The following is a description of a gene set: Pan-Hdac inhibitors (HDACi) are endowed with a potent anti-inflammatory activity, but the relative role of each of the eleven Hdac proteins sensitive to HDACi to the inflammatory gene expression program is unknown. Using an integrated genomic approach we found that Hdac3-deficient macrophages are unable to activate almost half of the inflammatory gene expression program when stimulated with lipopolysaccharide (LPS). A large part of the activation defect is due to loss of basal and LPS-inducible expression of IFNb, which in basal cells maintains Stat1 protein levels, and after stimulation acts in an autocrine/paracrine manner to promote a secondary wave of Stat1-dependent gene expression. We show that loss of Hdac3-mediated repression of nuclear receptors leads to hyperacetylation of thousands of genomic sites and associated gene derepression. The upregulation of the constitutively expressed prostaglandin endoperoxide synthase, Ptgs1 (Cox-1), has a causative role in the phenotype, since its chemical inhibition reverts the Ifnb activation defect. These data may have relevance for the use of selective Hdac inhibitors as anti-inflammatory agents. Human Gene Set: GSE33162_UNTREATED_VS_4H_LPS_STIM_HDAC3_KO_MACROPHAGE_DN from publication Chen X, Barozzi I, Termanini A, Prosperini E, Recchiuti A, Dalli J, Mietton F, Matteoli G, Hiebert S, Natoli G (PMID 22802645) species: Homo sapiens Genes down-regulated in macrophages with knockout of HDAC3: untreated versus LPS., and this is the list of marker genes: TRAM1, SYCE2, TSPAN31, CMTM7, ITGB1, CD47, COMMD1, HJURP, FAM120A, ARL6IP1, PELO, TOP2A, ACADL, DDIT4, CAPRIN1, MRPL42, NUSAP1, IDE, MRPL4, AURKB, STIL, CKS1B, RPA2, SEPTIN11, FKBP5, TBCB (tubulin folding cofactor B), SNX10, RPN2 (ribophorin II), COPB1, SPCS3, AKR1A1, PGP, NUDT21, TUBA1B, RPN1, STARD3NL, GTF3A, KIF20A, RAD51AP1, AK3, MELK, DUT (deoxyuridine triphosphatase), LACTB2, CX3CR1, CDC20, MTHFD1, PRF1, SLC25A24, SLC38A10, LGALS1, GOT2 (NCBI Gene Id 2806), GLUD1, PRIM2, ACOT7, FANCF, CLPTM1L, EBP, GNG2, SMS, CBX5, KIF11, XPO1, LAG3, SRSF1, C2orf49, PAPOLA, GLOD4, HPF1, SAE1, GNA15, NCAPD2, SLC35B1, MCM3, IL18RAP, SDF2L1, PSMD14, MAD2L1, TRIM37, CISD1, ANP32E, GMNN, MYDGF, CXCR6, LIG1, CENPF, CA5B, ELOVL1, PRDX2, FH, SLC16A6, PGLYRP1, CCNE1, SUMO3, MCM2, SDCCAG8, CYBA, TMBIM4, APOBEC2, USP1, RAB8B, MTCH1, CLIC1, ETFB, ACSL5, AS3MT (arsenite methyltransferase), MCM6, PLK1, HDGF, UBXN2B, CAPZA1, COX17, CENPV, SACM1L, HMBS, ZBTB32, ABRACL, SOAT2, AKIP1, PLK4, DTYMK, AQP1 (aquaporin 1 (Colton blood group)), TRAPPC1, IDH3A, MPO, STK39, CRIP2, NQO2, AKT1, TAL1, TCF19, HPRT1, BUB1B, TMED3, HIF1A, TIPIN, ZWILCH, SRP19, LRRK1, STARD10, BSCL2, PGK1, DNA2, TUBB4B, PPP1CA, GARS1, TPPP3, SLC43A3, ACTR1A (actin related protein 1A), DIAPH3, EDEM2, BLMH (bleomycin hydrolase), PYCARD, ARPC5, NUDT4, ACSBG1, MTHFD2, INCENP, PRTN3 (NCBI Gene Id 5657), PBK, XPNPEP1, VDAC2, AHCY (adenosylhomocysteinase), TRIP13, RDM1, NKAP, HOPX, ILK, TUBGCP2, SNRPA, DESI1, RTCA, FUT8, SMAP1, ICOS, POPDC2, SDCBP2, MED30, DLGAP5, S100A11, ESM1, MKI67, CTSD, EFHD2, SMC2, NDUFB7, ITGAX, DPP3, IMPA1, RFWD3, PRDX1, CHAF1B, MINDY3 (NCBI Gene Id 80013), NUCKS1, SELENOH, TPX2, ESD, AP3S1, JPT1, MCM7, ITGB1BP1